The following is a description of a gene set: Limb hypertonia studied in species Homo sapiens Human Gene Set: HP_LIMB_HYPERTONIA, and this is the list of marker genes: CAMSAP1, KIDINS220, PRPS1, WWOX, DNAJC6, WARS2, ATP6V1A, DHDDS, EMC1, SLC31A1, GNB1, GCH1, PIGP, CYFIP2, SLC13A5, DPH5, UFC1, SRPX2, SYNGAP1, ERCC6, PIGA, KIFBP, FA2H, NDUFA9, ASNS, SEPSECS, GABBR2, FZR1, CDK19, SCN8A, POLR3A, UBA5, TSEN2, PI4KA, MINPP1, DNAJC12, PCCA, GABRG2, H4C5 (H4 clustered histone 5), ARV1, KDM1A, SCN3A, CDC42BPB, LBR, SDHB (succinate dehydrogenase complex iron sulfur subunit B), COG4, SLC39A14, CELF2, SLC35C1, MTRR (5-methyltetrahydrofolate-homocysteine methyltransferase reductase), UFSP2, PACS2, KCNA2, ALDH18A1, RNU7-1, FOXG1, TSEN34, SLC38A3, NECAP1, OSTM1, NTRK2, DHPS (NCBI Gene Id 1725), FBXO28, NCAPD3, ATP1A2, USP8, CNKSR2, PARS2, AFG2A, SLC33A1, CLTC, GRM7, TRAK1, KCNB1, ASXL1, RARS1, SLC30A9, GABRA2, PNPT1, EEF1A2 (NCBI Gene Id 6669), TSEN54, AARS1 (alanyl-tRNA synthetase 1), WDR48, PI4K2A, ADCY5, KCNC2, YWHAG, GRIK2 (glutamate ionotropic receptor kainate type subunit 2), CACNA1B, GRIN2D (NCBI Gene Id 9164), ATP1A3, SCO2, ERCC8 (NCBI Gene Id 2075), SDHA, KIF5A, DDC, GPHN, UBTF, PTS, SPTAN1, ATL1, SLC6A3, SDHD, PCCB, ARSI, TARS2, GFM2, MED11, HCN1, EBP, CACNA1A, KATNB1, SPG7, PRDM13, SYNJ1, DNM1, ALG11, PYCR2, AFG3L2, SLC25A19, SMG9, CLDN11, PLAA, DYRK1A, BRF1, DALRD3, FRMD4A, AP3B2, CACNA2D1, GABRB2, PPP3CA, BRAT1, FGF13, ESAM, ASXL2, TSEN15, AP4M1, NUS1, SLC16A2, SPR, ERCC1, FGF12, ELOVL4, KDM5C, ADGRG1, CLP1, RHOBTB2 (NCBI Gene Id 23221), IFIH1, NDUFC2, KAT6A, MTPAP, HK1, ATRX, SDHAF1, CACNA1G, DOCK6, SZT2, SLC1A2 (solute carrier family 1 member 2), ACTL6B, VPS37A, SCN1A, GABRA5, GDAP2